The following is a description of a gene set: studied in species Homo sapiens Human Gene Set: HP_PAIN_INSENSITIVITY Pain insensitivity Inability to perceive painful stimuli., and this is the list of marker genes: NGLY1, TDP1, ZFHX2, TRPM3, CACNA2D1, ATL3, MPV17, MECP2, SNUPN, NTRK1 (NCBI Gene Id 7825), GRIA3, DDHD1, CLTCL1, KDM5C, RAI1, ATL1, SPTLC2, SCN9A, NGF, TRIO, EBF3, HDAC4, DEAF1, SCN11A, TMEM218, RFX7, PRDM12, DNM1L, IARS2, SPTLC1